The following is a description of a gene set: from publication Hu J, Bianchi F, Ferguson M, Cesario A, Margaritora S, Granone P, Goldstraw P, Tetlow M, Ratcliffe C, Nicholson AG, Harris A, Gatter K, Pezzella F (PMID 15592519) Up-regulated genes that separate angiogenic from non-angiogenic non-small cell lung carcinoma (NSCLC) samples. studied in species Homo sapiens Human Gene Set: HU_ANGIOGENESIS_UP Angiogenesis is regarded as essential for tumour growth. However, we have demonstrated that some other aggressive non-small-cell lung carcinomas (n-SCLC) do not have angiogenesis. In this study, using cDNA microarray analysis, we demonstrate that angiogenic and nonangiogenic tumour types can be distinguished by their gene expression profiles. Tissue samples from 42 n-SCLC patients were obtained with consent. In all, 12 tumours were nonangiogenic and 30 angiogenic. The two groups were matched by age, sex, smoking and tumour stage. Total RNAs were extracted followed by microarray hybridization and image scan procedure. Data were analysed using GeneSpring 5.1 software. A total of genes were found to be able to separate angiogenic from nonangiogenic tumours. Nonangiogenic tumours have higher levels of genes concerned with mitochondrial metabolism, mRNA transcription, protein synthesis and the cell cycle. Angiogenic tumours have higher levels of genes coding for membrane vesicles, integrins, remodelling, angiogenesis and apoptosis. These results further support our first finding that nonangiogenic lung tumours are fast-growing tumours filling the alveoli in the absence of vascular remodelling. We raise the hypothesis that in nonangiogenic tumours, hypoxia leads to a higher activation of the mitochondrial respiratory chain, which allows tumour growth without triggering angiogenesis., and this is the list of marker genes: HECW1, FOS, PRODH, NMD3, CAMK2D, PIK3R1, STUB1, SEMA3C (NCBI Gene Id 222200), LCAT, RND3, TSSK1A, SIPA1L1, ITGB4, THBS1, JADE2, NRGN, FAH, NAPG, COL7A1, STXBP1, CLTA